Given this list of marker genes Zbtb14, Rlig1, Dpysl5, Azi2, Ewsr1, Bbip1, Rbm15b, Pak1, Cfap20, Jmy, Hmgxb4, Tnik, Larp4b, Ube2d2a, Rbbp4, Tgfa, Nptn, Snap25, Relch, Hepacam2, Dlg5, Zfp141, Snx13, Nol8, Prrc2c, Lmtk2, Fbxw7 (F-box and WD-40 domain protein 7), Gm3696, Cnpy1, Sco1, Rnf103, Ttc14, Qki, Gucy1a2, P2ry4, Elovl5, Zfp334, Gm2897, Apc, Eif3a, Nr4a3, Gm3558, Gria3, Zbtb37, Paqr9, Gm3636, Idh3a, Gm3500, Zfp558, Arf6, Naa30, Zswim6, Sgk1, Opcml, Gm3411, Lepr, F9, Cacna1c, Zmiz1, Nabp1, Smad5 (NCBI Gene Id 76327), Agmo, Mef2c, Msn, Tafa4, Aggf1, Slc35a3, Cldn5 (NCBI Gene Id 21920), Smc3, Lmo7, Semp2l2a, Gna14, Nfib, Peak1, 4930555G01Rik, Extl2, Adam23, Tnrc18, Mex3c, Rap1a, Lsm11, Mapk6, Prrg1, Dmxl1, Gm5796, Crxos, Gpn1, Ugt2b34, Kif15, Slc35a2, Gm3317 (NCBI Gene Id 666329), Bach2, Ssr3, Elk3, Lss, Klhl11, Atp2b2, Hibch (3-hydroxyisobutyryl-Coenzyme A hydrolase), Hnrnpa0, Kdm5a, Zc3h13, Kpna4, Arid2, Mink1, Gm3383, Erbb4, AI597479, Siglech, Pag1, Gm3488, Evi5, Hipk3, Rbm4b, Akap6, Morc2a, Gm266, Gm10406, Eid2b, Ccpg1, Tspan9, Steap4, Septin7, Cdyl2, Etf1, Csgalnact2, Lrrtm4, Cdc25a, Pcbp3, Mapk1, 1110004F10Rik, Ino80d, Colgalt2, Dynll1 (NCBI Gene Id 56455), Aard, Tet1, Fbln1, Akirin1, Kif5b, Lbh, Dsg3, Tmem69 (transmembrane protein 69), Synpo2l, Otud1, Ascc3, Atp9a, Ccdc116, Rock2, Glra2, Chst1, A4galt, Ncbp1, here is a description of the gene set: from publication Chen Y, Wang X (PMID 31504780) Mouse Gene Set: MIR_6715_3P species: Mus musculus Genes predicted to be targets of miRBase v22 microRNA mmu_miR_6715_3p in miRDB v6.0 with MirTarget v4 prediction scores > 80 (high confidence targets).